Given this list of marker genes Bmpr1b, Nppc, Ereg, Ptx3, Tnfaip6, Npr2, here is a description of the gene set: species: Mus musculus The stage in oogenesis when the antral spaces fuse to form a single antral space. The oocyte is suspended in the cumulus oophorous and the first polar body in the perivitelline space. Mouse Gene Set: GOBP_FUSED_ANTRUM_STAGE